Given this list of marker genes STRC, CDC14A, DCDC2, CDH23, MKKS, RAC1, ELMOD3, GRXCR1, RSPH9, STRCP1, KNCN (NCBI Gene Id 148930), IFT20, here is a description of the gene set: Human Gene Set: GOCC_KINOCILIUM species: Homo sapiens A nonmotile primary cilium that is found at the apical surface of auditory receptor cells. The kinocilium is surrounded by actin-based stereocilia.